The following is a description of a gene set: studied in species Homo sapiens Progeroid facial appearance Human Gene Set: HP_PROGEROID_FACIAL_APPEARANCE A degree of wrinkling of the facial skin that is more than expected for the age of the individual, leading to a prematurely aged appearance., and this is the list of marker genes: ERCC4, KCNJ6, ERCC6, STUB1, RECQL, POLR3A, SLC2A10, ATP6V0A2, ERCC8, FBN1, ZMPSTE24, ELN, EXOSC2, LMNB2, CAV1, BANF1, WRN, ERCC1, COG4, LTBP4, GJB6, GORAB, MTX2, LMNA, ERCC3, B4GALT7, RNF113A, PSMB8, PCNA, GJB2